The following is a description of a gene set: Cerebral hypomyelination Human Gene Set: HP_CEREBRAL_HYPOMYELINATION species: Homo sapiens Reduced amount of myelin in the nervous system resulting from defective myelinogenesis in the white matter of the central nervous system., and this is the list of marker genes: PHGDH, TMTC3, RARS1, GJC2, PGAP2, AFG2A, SLC1A4 (NCBI Gene Id 6509), PIGO, VPS11, AHDC1, ADSL (adenylosuccinate lyase), PGAP3, PIGW, CYB5A, PIGL, SOX10, STXBP1, POLR3B, ALG2, PLP1, BCAP31, EIF2B1, WDR26, PIGV, MTHFS, PIGY, CYB5R3, TBCD, HYCC1, SLC25A12, TUBB4A